The following is a description of a gene set: from publication Magrangeas F, Nasser V, Avet-Loiseau H, Loriod B, Decaux O, Granjeaud S, Bertucci F, Birnbaum D, Nguyen C, Harousseau JL, Bataille R, Houlgatte R, Minvielle S (PMID 12623842) Human Gene Set: MAGRANGEAS_MULTIPLE_MYELOMA_IGLL_VS_IGLK_UP species: Homo sapiens Up-regulated genes discriminating multiple myeloma samples by the ype of immunoglobulin light chain they produce: Ig lambda (IGLL) vs Ig kappa (IGLK). Although multiple myeloma (MM) is a unique entity, a marked heterogeneity is actually observed among the patients, which has been first related to immunoglobulin (Ig) types and light chain subtypes and more recently to chromosomal abnormalities. To further investigate this genetic heterogeneity, we analyzed gene expression profiles of 92 primary tumors according to their Ig types and light chain subtypes with DNA microarrays. Several clusters of genes involved in various biologic functions such as immune response, cell cycle control, signaling, apoptosis, cell adhesion, and structure significantly discriminated IgA- from IgG-MM. Genes associated with inhibition of differentiation and apoptosis induction were up-regulated while genes associated with immune response, cell cycle control, and apoptosis were down-regulated in IgA-MM. According to the expression of the 61 most discriminating genes, BJ-MM represented a separate subgroup that did not express either the genes characteristic of IgG-MM or those of IgA-MM at a high level. This suggests that transcriptional programs associated to the switch could be maintained up to plasma cell differentiation. Several genes whose products are known to stimulate bone remodeling discriminate between kappa- and lambda-MM. One of these genes, Mip-1alpha, was overexpressed in the kappa subgroup. In addition, we established a strong association (P =.0001) between kappa subgroup expressing high levels of Mip-1alpha and active myeloma bone disease. This study shows that DNA microarrays enable us to perform a molecular dissection of the bioclinical diversity of MM and provide new molecular tools to investigate the pathogenesis of malignant plasma cells., and this is the list of marker genes: TLX1, CSNK2A2, CYB5A, ZMYM2, FAS (Fas cell surface death receptor), FGR, NFE2L3, BPHL, CTSB, RECQL5, PRKCI, CCL3, CDC42EP3, EXT1, CUL4A, EDN3, DDR1, IGKC, MALT1, TNK2 (tyrosine kinase non receptor 2, NCBI Gene Id 10188), RB1, PICK1, YEATS4, BMP2, HBG2, UBE3A, NFKB1, SH3GL2, NR2C1, DSG1, CDK1, ELAVL4, HSD17B2, PLXNB3, NFIX, MYB, GSTM5, TGFB3, LAMB3, SMARCA1, SIAH2